The following is a description of a gene set: Human Gene Set: GSE45365_WT_VS_IFNAR_KO_CD11B_DC_MCMV_INFECTION_DN studied in species Homo sapiens Genes down-regulated during primary acute viral infection in ITGAM+ dendritic cells: wildtype versus IFNAR1 knockout. Murine Cytomegalovirus (MCMV) infection leads to early activation of various immune cells, including B and T lymphocytes, before the actual initiation of antigen-specific adaptive immunity. This activation is partly driven by innate cytokines, including type I interferon (IFN), which are induced early after infection. The objective of this study was to address the role of type I IFN in shaping early/innate B and T cell responses to a primary acute viral infection. In order to decipher the specific impact of IFN-I on cell subsets, we performed a genome-wide expression analysis on WT splenic B and CD8 T lymphocytes isolated from C57BL/6 mixed bone marrow chimera mice. This study complements series GSE39555, which focused on early responses of NK cells and of the two subsets of conventional dendritic cells., and this is the list of marker genes: PRTN3, RDM1P5, GNRH1, CDSN, SFTPD, SLC25A31, MTFR2, BAZ2B-AS1, SLC16A3, PSAT1, CENPE, LINC02243, SPHKAP, PCOLCE2, ACADL, KIF4A, CENPF, BCAR3, CDKN3, UPK1B, IL17A, PRC1, LDHC, GRIN3A, SLC16A4, CDCA5, AK5, HTR1E, DEFT1P, CYP2F1, KCNK2, LINC00626, DDIAS, DHFR, DTL, AIG1, SORCS3, DEFB129, DLGAP5, HISLA (NCBI Gene Id 283587), ESYT3, HPYR1, GNAO1-DT, TESMIN, TOP2A, DEPDC1, CT83, MIR503HG, GINS1, SHCBP1, E2F8, MELK, RFLNB, NPHP3-AS1, HTN1, NUF2, DLG1-AS1, MEIS2, OTOGL, IGHV7-81, SPAG5, TPX2, NME8, TBX3, PLD5, SNHG4, CNTNAP4 (NCBI Gene Id 85445), CCNB2, DIO1, TSSK3, MYO10, TECTB, PPEF2, FAP, MND1, AURKA, NAV3, SCGB1A1, STAM, DSG1, ASPM, CEACAM21, NLGN1, BPI, C15orf48, IL17RC (interleukin 17 receptor C), FRK, DRD2, SIX2, UMODL1, CALM3, GTF3C2-AS1, LINC01426, LRRC2, SKA3, GNA14, SLC2A10, CERS3, TKT, CEP55, CDC20, DCDC1, LINC02961, HRH1, PCDHB4, ZNRF2P1, ARF5, HBS1L, DNAH10, MAL2, JAG1 (NCBI Gene Id 3715), POPDC3, CEACAM1, CLDN1, GADD45G, HELB, MC4R, WNT5A, PRKAG3, REXO5, PABPC1L2B, AMPD3, UBE2S, NPY6R, AGR3 (NCBI Gene Id 155465), CBLIF, ATP13A3-DT, PTGR1, TK2, FGD5, C20orf181, TRIOBP, MIR9-1HG, CCDC141, CDC25C, SLC40A1, SLC25A48-AS1, KHDC1, TK1, TRPM1, SAMD9L, HMMR (hyaluronan mediated motility receptor), DIRAS3, BCL2L14 (BCL2 like 14), ATP8B4, MCU, PAK1, TRIP13, GAS2, MKI67, SPATA31F2P, TMEM169, FOXM1, SHOC1, RBM11, KIF20A, BCL9, UBE2C, CDK1, ARSB, ANTXR1, PLK4, ZNF462 (zinc finger protein 462), DAW1, KDELR3, CDCA3, CIB4, DHCR7, TEX15, CYP19A1, PLCB4, LINC01949, LINC00470, TMEM26, H2BC8, ATOH7, PRTG, CYP2B7P (NCBI Gene Id 1556), CDCA8, SLC5A12, SMIM7, H2BC12, ENPP3, TPRXL, LMNTD1, TEDDM1, TMEM132D (transmembrane protein 132D), REC8, ARHGEF37, TBX5-AS1